The following is a description of a gene set: Human Gene Set: HP_MEGAKARYOCYTE_NUCLEUS_HYPERLOBULATION Megakaryocyte nucleus hyperlobulation The presence of megakaryocytes in the bone marrow whose nuclei are more lobulated than expected for the size of the nucleus. species: Homo sapiens, and this is the list of marker genes: CALR, SH2B3 (SH2B adaptor protein 3), TP53, TET2, MPL, JAK2